The following is a description of a gene set: Reactome Pathway: NEIL3-mediated resolution of ICLs species: Homo sapiens DNA glycosylase activity of NEIL3 is involved in resolution (unhooking) of psolaren-induced interstrand crosslinks (ICLs), as well as abasic site-induced ICLs (AP-ICLs) in a Fanconia anemia (FA) pathway-independent fashion. part of: Base-Excision Repair, AP Site Formation, and this is the list of marker genes: NEIL3